The following is a description of a gene set: Systems biology approaches have recently provided new insights into the mechanisms of action of human vaccines and adjuvants. Here, we investigated early transcriptional signatures induced in whole blood of healthy subjects following vaccination with a recombinant HIV-1 envelope glycoprotein subunit CN54gp140 adjuvanted with the TLR4 agonist glucopyranosyl lipid adjuvant-aqueous formulation (GLA-AF) and correlated signatures to CN54gp140-specific serum antibody responses. Fourteen healthy volunteers aged 18-45 years were immunized intramuscularly three times at 1-month intervals and whole blood samples were collected at baseline, 6 h, and 1, 3, and 7 days post first immunization. Subtle changes in the transcriptomic profiles were observed following immunization, ranging from over 300 differentially expressed genes (DEGs) at day 1 to nearly 100 DEGs at day 7 following immunization. Functional pathway analysis revealed blood transcription modules (BTMs) related to general cell cycle activation, and innate immune cell activation at early time points, as well as BTMs related to T cells and B cell activation at the later time points post-immunization. Diverse CN54gp140-specific serum antibody responses of the subjects enabled their categorization into high or low responders, at early ( < 1 month) and late (up to 6 months) time points post vaccination. BTM analyses revealed repression of modules enriched in NK cells, and the mitochondrial electron chain, in individuals with high or sustained antigen-specific antibody responses. However, low responders showed an enhancement of BTMs associated with enrichment in myeloid cells and monocytes as well as integrin cell surface interactions. Flow cytometry analysis of peripheral blood mononuclear cells obtained from the subjects revealed an enhanced frequency of CD56<sup>dim</sup> NK cells in the majority of vaccines 14 days after vaccination as compared with the baseline. These results emphasize the utility of a systems biology approach to enhance our understanding on the mechanisms of action of TLR4 adjuvanted human vaccines. species: Homo sapiens from publication Anderson J, Olafsdottir TA, Kratochvil S, McKay PF, Östensson M, Persson J, Shattock RJ, Harandi AM (PMID 29535712) Human Gene Set: ANDERSON_BLOOD_CN54GP140_ADJUVANTED_WITH_GLA_AF_AGE_18_45YO_1DY_UP Genes up-regulated in blood 1d vs 0hr in adults (18-45) after exposure to CN54gp140 adjuvanted with GLA-AF, time point 1D, administered i.m., and this is the list of marker genes: IGFBP1, RXRG, H3-4, AMY1B, FAM162A, HS3ST6, SOD2-OT1, ARTN, HCN2, ZNF93, CD48, CASTOR1, RASSF6, BOLA2, LINC01618, PLA2G3, ZNF320, PKP2, SMIM30, ITM2B, KRT75, TMEM191A, PHLDB1, RBMX2, RPS18, SRGAP2C, SNORD13, FAM89A, CRB3, HLA-C, ADRA2C, NR2F2, PRDX4, SNTA1, IER3IP1, FUT8-AS1, TMEM70, C4orf3, QNG1, GOLGA6L7, SNX14, ING3, ZNF160, RUNX1T1, OR52D1, MIR488, KRTAP10-2, BMP8B, SPINK2, SIGLEC6, MTX2, KCTD7, GIMAP2, SNORD3D, PCYOX1, FSTL4, IL17REL, BANF2, MRPL15, CAPZA1 (capping actin protein of muscle Z-line subunit alpha 1), SYP, CSNK1G1, HBE1, TMSB4X (NCBI Gene Id 7114), ATAD1, NRSN2 (NCBI Gene Id 80023), BRIX1, PRKACG, ENSA, IFT70A, NALF2, CAMK2A, SCGN, RNF7, EID3, STAR, GUCA2A, CAMK1G, MAPK8IP2, SUMO1, ATP11C, RNASEH2B, RFX4, TMEM106B, GCLM, TAFAZZIN